Given this list of marker genes TUBB4A, FTL, VPS13A, KCTD17, THAP1, PRKRA, POLR1A, GNAL, KMT2B, STX16, GNAS, VPS11, TSPOAP1, COL6A3, ATP5MC3, here is a description of the gene set: A form of focal dystonia that affects the vocal cords, associated with involuntary contractions of the vocal cords causing interruptions of speech and affecting the voice quality and often leading to patterned, repeated breaks in speech. Laryngeal dystonia studied in species Homo sapiens Human Gene Set: HP_LARYNGEAL_DYSTONIA